Given this list of marker genes FGF2, SPRED3, ZEB2, CDKN1B, SPRY1, SPRY2, SPRED2, FOXE3, SPRED1, CDKN1C, here is a description of the gene set: species: Homo sapiens Human Gene Set: GOBP_REGULATION_OF_LENS_FIBER_CELL_DIFFERENTIATION Any process that modulates the frequency, rate or extent of lens fiber cell differentiation.